Given this list of marker genes Ahi1, ENSMUSG00000141905, Asns, Slc7a11, Ermp1, Chac1, Iapp, Plcl1, Ccdc7b, Uchl1, Grem2, Rnf187, Ifi207 (NCBI Gene Id 98407), B230217O12Rik, Ero1a, Dscaml1, Klhl4, Mlf1, Arhgap22, Tle4, Akr1c12, Bcs1l, Npy1r, Cys1, here is a description of the gene set: Mouse Gene Set: GAUSSMANN_MLL_AF4_FUSION_TARGETS_C_DN species: Mus musculus from publication Gaussmann A, Wenger T, Eberle I, Bursen A, Bracharz S, Herr I, Dingermann T, Marschalek R (PMID 17130830) Down-regulated genes from the set C (Fig. 5a): specific to cells expressing AF4-MLL fusion protein alone. The reciprocal chromosomal translocation t(4;11) is correlated with infant, childhood, adult and therapy-related high-risk acute leukemia. Here, we investigated the biological effects of MLL.AF4, AF4.MLL or the combination of both reciprocal fusion proteins in a conditional in vitro cell culture model system. Several parameters like cell growth, cell cycling capacity, apoptotic behavior and growth transformation were investigated under physiological and stress conditions. Co-transfected cells displayed the highest resistance against apoptotic triggers, cell cycling capacity and loss-of-contact inhibition. These analyses were complemented by gene expression profiling experiments and specific gene signatures were established for each of the three cell lines. Interestingly, co-transfected cells strongly upregulate the homeobox gene Nanog. In combination with Oct4, the Nanog homeoprotein is steering maintenance of pluripotency and self-renewal in embryonic stem cells. Transcription of Nanog and other stem cell factors, like Oct4 and Bmi1, was verified in biopsy material of t(4;11) patient cells which express both reciprocal t(4;11) fusion genes. In conclusion, the presence of both reciprocal MLL fusion proteins confers biological properties known from t(4;11) leukemia, suggesting that each of the two fusion proteins contribute specific properties and, in combination, also synergistic effects to the leukemic phenotype.